The following is a description of a gene set: Human Gene Set: MIR1282 studied in species Homo sapiens Genes predicted to be targets of miRBase v22 microRNA hsa-miR-1282 in miRDB v6.0 with MirTarget v4 prediction scores > 80 (high confidence targets). from publication Chen Y, Wang X (PMID 31504780), and this is the list of marker genes: TMEM263, ZZEF1, CAVIN2, SSX4B, TRIAP1, SSX7, SSX2B, RNASE11, TSPAN12, FBRSL1, SSX4, SSX1, SSX5, PLCH1, SLC66A1LP, TFEC, SAR1B, PLIN1, SSX2, SSX3